The following is a description of a gene set: Sub-pathway for representing the pentose phosphate pathway gene regulated by NFE2L2 (NRF2). NFE2L2 directs the transcription of genes related to the Pentose Phosphate pathway which helps in programming the metabolic pathway to cope with oxidative stress and also has a significant role in cancer progression part of: Nuclear events mediated by NFE2L2 studied in species Homo sapiens Reactome Pathway: NFE2L2 regulates pentose phosphate pathway genes, and this is the list of marker genes: TALDO1, PGD, NFE2L2 (NFE2 like bZIP transcription factor 2), G6PD, CREBBP (CREB binding protein), TKT, EP300, MAFG (MAF bZIP transcription factor G)